The following is a description of a gene set: Th1 and Th2 cells arise from a common precursor cell in response to triggering through the TCR and cytokine receptors for IL-12 or IL-4. This leads to activation of complex signaling pathways, which are not known in detail. Disturbances in the balance between type 1 and type 2 responses can lead to certain immune-mediated diseases. Thus, it is important to understand how Th1 and Th2 cells are generated. To clarify the mechanisms as to how IL-12 and IL-4 induce Th1 and Th2 differentiation and how TGF-beta can inhibit this process, we have used oligonucleotide arrays to examine the early polarization of Th1 and Th2 cells in the presence and absence of TGF-beta after 0, 2, 6 and 48 hours of polarization. species: Homo sapiens Human Gene Set: GSE2770_TGFB_AND_IL4_VS_IL4_TREATED_ACT_CD4_TCELL_6H_UP from publication Lund R, Aittokallio T, Nevalainen O, Lahesmaa R (PMID 14607935) Genes up-regulated in CD4 T cells activated by anti-CD3 and anti-CD28: TGFB1 and IL4 (6h) versus IL4 (6h)., and this is the list of marker genes: PKP4 (NCBI Gene Id 8502), NCBP2AS2, SIGMAR1, PRPF8, URI1, LEF1-AS1, USP5, ASAP1, LCP2, ZNF678 (NCBI Gene Id 84841), RBCK1, MT1X, GSTM1, LGALS9, ZZZ3, CHM, ATG16L2, TMEM242, RFFL, TRIP4, WAS, TMED4 (transmembrane p24 trafficking protein 4), PFKL, CCDC88B, PCCB, ZGPAT, SMC1A, LINC00667, RNPEPL1, CTSO, MALT1, MCTS1, TLK1, MYBL1, DHX35, CMPK2, ACP6, COQ9, ECI1, PLEK, TSC1 (NCBI Gene Id 7248), COA5 (NCBI Gene Id 493753), SSBP3, ARHGEF18, CTSH (cathepsin H), HSBP1L1, IGLV1-44, FRS2, ACP5, SMIM19, NIFK-AS1, SLC1A1, NEK8, SPIN3, VPS28, SMAD2 (SMAD family member 2), NPTXR, CD47, UBE2Q2P13, FCGRT, MEST, KRI1, GRIPAP1, EPHB6, CAD, SVBP (NCBI Gene Id 374969), GTPBP8, IL18BP, DLG1, SNRNP200, DERL3, FOXM1, NDUFB8, NDUFA1, RBM41, STIM2, PSMB3, CRIP1, LDAH, LSM12, ICE2, FAM226B, ZNF559, PEPD, GMEB1, PEX14 (peroxisomal biogenesis factor 14), FKRP, KATNBL1, NSUN5, TGOLN2, THOC2, SHPRH, TMEM200A, KMT2D, SPAG7, CBLB, MLH3, TRAK1, PRKCB, TCF7, C6orf89, MARCHF9 (membrane associated ring-CH-type finger 9), LRRC37A2, COMMD1, DENND6A, RERE, MTOR, PCF11, GDPD5, DCPS, STAG1, PPA2, D2HGDH (NCBI Gene Id 728294), PAM16, DDX60, MORC2, NKTR, CCDC14, FLT3, DUSP12, SMCR8 (NCBI Gene Id 162633), ANGEL2, ATG7, MS4A3, DNAJC13, NDUFA11, MED11, MID1, TYSND1, DUS4L, DDRGK1, ADAT1, TNFRSF14-AS1, AUH, MCM5, SPMIP4, GGT1, DHX30, RPP25L, DNAJC19, EPHA1-AS1, GPA33, MANBAL, ANKEF1, OMA1, NDUFB2-AS1, TMEM218, RECQL5, FCER1G, NBN, B3GALT6, SMARCB1, SLC35A5, CLSTN1, TTC5, MRTFB, POFUT1, SNRNP35, SOCS2, MAP2K7, CSAD, OFD1, PLEKHB1, CASK, NABP2 (NCBI Gene Id 79035), NOL4L, CD96, DRAM2, NAXD, MUC1, OCLN, EIF2D, MAP2K2, C12orf76, PRMT7, SCRN1, MUTYH, TCEAL1, SELENOW, NUDT6, MTA1, OSGEPL1, GTF3C3, MAN2C1, VPS36 (NCBI Gene Id 51028), EBAG9 (NCBI Gene Id 9166), UBA5, HDAC1, IL4R, VILL, RAB1B, MAF1, PSMA3-AS1, ZNF836